Given this list of marker genes EEF1A1, SNRNP70, SNCA, EEF1A2, CTSA, GFAP, PLK3, ATP13A2, here is a description of the gene set: Any process that modulates the frequency, rate or extent of chaperone-mediated autophagy. studied in species Homo sapiens Human Gene Set: GOBP_REGULATION_OF_CHAPERONE_MEDIATED_AUTOPHAGY